The following is a description of a gene set: species: Homo sapiens from publication Longo NS, Lugar PL, Yavuz S, Zhang W, Krijger PH, Russ DE, Jima DD, Dave SS, Grammer AC, Lipsky PE (PMID 19023113) Genes down-regulated in comparison of IgD- peripheral blood B cells versus dark zone germinal center B cells. Human Gene Set: GSE12845_IGD_NEG_BLOOD_VS_NAIVE_TONSIL_BCELL_DN B cells from human tonsil and blood were sorted using flow cytometry. The human samples were processed immediately ex-vivo using markers for known B cell subsets., and this is the list of marker genes: TNP2, ZBTB43 (NCBI Gene Id 90789), ETF1, KANSL2, SLC50A1, HK2, PLA2G10, NAT10 (N-acetyltransferase 10), SATB1 (NCBI Gene Id 6304), ZNF160, SNORA21, AGPAT2, PPP4R3A, MUTYH, MMP17, CCN2, MBP, UTP20, ITPR3, RPS6KA1, CLEC4A, ARID1A, PIPOX, USP8, FILIP1L, TENT5A, CSRNP2, DDR1 (discoidin domain receptor tyrosine kinase 1), MATK, SLC35E1, SNRNP25, ZNF500, LGALS8, GUSBP14, SRSF11, PHLPP1, LPIN1, POLE, MED1, SGSM3, KDM2A, RABEP1, NEK1, R3HDM2, RBM23, ANKRD11 (ankyrin repeat domain containing 11), CYTIP, TTC31, PLIN1, TACC1, DEF6, ZNF148, MAPK1IP1L, CIC, CCIN, APPL2, PCDH11Y, CLCN7, ARHGEF9, CYP2R1, IKZF5, DCAF13, C1QTNF1, DDC, ARID5A, ARHGEF1, PRKRIP1, LDOC1, CHML, NLRP1, MAPK8IP3, MEIS3P1, NOTCH1, PDP1, RSRC1, GMFB, NUP58, GADD45A, GTPBP8, NUDCD3, KCNAB2, KLHL24, SYNE1 (NCBI Gene Id 85448), SH3BP2, ALDOC, CRTC3, SARAF, B4GALT5, PLEKHA1, LASP1, CHD3, ZNF862, ASAP1, MRPL52, TNFRSF10D, MACF1, MARCKSL1, RBM7, PDE4C, SPIN1, MFNG (NCBI Gene Id 4242), PHF1, GNRH2, ODF1, ZNF611, PDE8A, MMP2, PADI1, NR4A1, RNF44, WBP11, RERE, RAD54B, MTCL1, CIRBP, JAM2, NR1D2, CHP2, KRT14, ZNF117, TGFB1, CCNL1, XRCC2, FAM169A, ATG101, ZNF692, OLFM1 (olfactomedin 1), TBC1D1, RASSF2, GLIPR1, C1orf115, SMPD1, TMEM109, CYTH4, TNFSF13, INVS, CHST11, CD6, TRIB2, GYPC, WDR74, CMTR1, SLC66A2, FBXO41, ZNF669, CD22, MTMR6, SPG7, PRR14L, DENND3, RXRA, MAFF, ZNF10, TGFB3, CHI3L2, MAT2A, PPM1F, DACT1, IL6, PGF, DUSP4, DENND4B, CHKA, EIF4A3, ASTE1, BTBD3, SLA, POLR2A, SPAG4, CWC25, TRMO, NCAPH2, SKAP1, BHLHE40, RHOT2, CHL1, SUGP2, TMBIM4, ZC3H15, POLR1B, PROP1, CDKN1A, KLF10, SOX4, CKAP2, SNIP1, CNR2, NKTR, HGSNAT, SIK1, AGPAT3, GIT1, LMBR1L, DNMT3A, RLF, HMGXB4, ATF4